The following is a description of a gene set: species: Homo sapiens Human Gene Set: GOBP_NEGATIVE_REGULATION_OF_MONOATOMIC_ION_TRANSMEMBRANE_TRANSPORT Any process that stops, prevents, or reduces the frequency, rate or extent of the directed movement of ions from one side of a membrane to the other., and this is the list of marker genes: MIR208A, TLR9, PCSK9, CALM2, NOS1, PLN, SLC26A5, SLN, KEL, OXSR1, STK39, PPIF, NEDD4L, CAB39, KCNE1, CACNA1F, GSTO1, PPP3CA, CRBN, RGS4, FMR1, KCNQ1, KCNH2, REM1, PPP3CB, ISCU, CALCA, MMP9, NEDD4, MIR30D, ATP1A2, MIR29B1, WWP2, OSR1, MIR448, PPP3R2, KCNRG, GRP, MIR499A, MIR212, MIR200C, GOPC, BCL2, CAMK2D, UBQLN1, NTSR1, KCNE3, KCNE2, KCNAB1, MIR103A1, YWHAE, CALM3, MIR328, COMMD1, UCP2, PRKCE, GPR35, VDAC1, PPP3R1, MIR192, BIN1, MIR24-1, SESTD1, TMBIM6, TGFB1, CAV3, FKBP1B, MCUB, SUMO1, SLC30A1, MIR208B, PPP3CC, CBARP, KCNE5, GNB5, MIR1-1, CRHR1, AGT, MIR26A1, ANK3, CALM1, TCAF2, UBR3, YWHAQ, HAMP, EPO, CAV1